The following is a description of a gene set: Genes translationally regulated in MEF cells (embryonic fibroblasts) in response to serum starvation and by rapamycin (sirolimus). Human Gene Set: BILANGES_SERUM_AND_RAPAMYCIN_SENSITIVE_GENES species: Mus musculus The tuberous sclerosis complex (TSC) proteins TSC1 and TSC2 regulate protein translation by inhibiting the serine/threonine kinase mTORC1 (for mammalian target of rapamycin complex 1). However, how TSC1 and TSC2 control overall protein synthesis and the translation of specific mRNAs in response to different mitogenic and nutritional stimuli is largely unknown. We show here that serum withdrawal inhibits mTORC1 signaling, causes disassembly of translation initiation complexes, and causes mRNA redistribution from polysomes to subpolysomes in wild-type mouse embryo fibroblasts (MEFs). In contrast, these responses are defective in Tsc1(-/-) or Tsc2(-/-) MEFs. Microarray analysis of polysome- and subpolysome-associated mRNAs uncovered specific mRNAs that are translationally regulated by serum, 90% of which are TSC1 and TSC2 dependent. Surprisingly, the mTORC1 inhibitor, rapamycin, abolished mTORC1 activity but only affected approximately 40% of the serum-regulated mRNAs. Serum-dependent signaling through mTORC1 and polysome redistribution of global and individual mRNAs were restored upon re-expression of TSC1 and TSC2. Serum-responsive mRNAs that are sensitive to inhibition by rapamycin are highly enriched for terminal oligopyrimidine and for very short 5' and 3' untranslated regions. These data demonstrate that the TSC1/TSC2 complex regulates protein translation through mainly mTORC1-dependent mechanisms and implicates a discrete profile of deregulated mRNA translation in tuberous sclerosis pathology. from publication Bilanges B, Argonza-Barrett R, Kolesnichenko M, Skinner C, Nair M, Chen M, Stokoe D (PMID 17562867), and this is the list of marker genes: UBA52, TMEM121B, PTMS, RPS19, RPS7, RPS9, QARS1, RPL10, LTA4H, FAU, SPRY2, RPL36A (NCBI Gene Id 6173), NBEA, EEF2, RPL18, EEF1B2, RPS5, RPL13, EXD2, COX7A2L (cytochrome c oxidase subunit 7A2 like), RBBP6, RPS24, RPS4X, RPS25, RPL21, RPL24, EIF3M, RPS27A, EEF1A1, RPS23 (ribosomal protein S23), RPS3, RPL30 (NCBI Gene Id 6156), RACK1, RPS14, RPL7, RPS16, EIF3H, RPL13A, EIF3F, RPS10, RPS17, RPS8, EEF1G, TPT1, RPL29, RPL14, CS, NOP53, RPL27A, SIN3B, RPL28, RPL6, USE1, RPL18A, C8G, RPL5, RPL8, RPL23 (ribosomal protein L23), RPS6, RPL26, RPL7A, RPL32, RPL15, RPS3A, EIF4B, RPL4, KCNK13, RPS13, EIF3L